The following is a description of a gene set: studied in species Homo sapiens Therapy with interferon-beta (IFN-beta) is a mainstay in the management of relapsing-remitting multiple sclerosis (MS), with proven long-term effectiveness and safety. Much has been learned about the molecular mechanisms of action of IFN-beta in the past years. Previous studies described more than a hundred genes to be modulated in expression in blood cells in response to the therapy. However, for many of these genes, the precise temporal expression pattern and the therapeutic relevance are unclear. We used Affymetrix microarrays to investigate in more detail the gene expression changes in peripheral blood mononuclear cells from MS patients receiving subcutaneous IFN-beta-1a. The blood samples were obtained longitudinally at five different time points up to 2 years after the start of therapy, and the patients were clinically followed up for 5 years. We examined the functions of the genes that were upregulated or downregulated at the transcript level after short-term or long-term treatment. Moreover, we analyzed their mutual interactions and their regulation by transcription factors. Compared to pretreatment levels, genes were identified as highly differentially expressed, many of them already after the first IFN-beta injection. The interactions between these genes form a large network with multiple feedback loops, indicating the complex crosstalk between innate and adaptive immune responses during therapy. We discuss the genes and biological processes that might be important to reduce disease activity by attenuating the proliferation of autoreactive immune cells and their migration into the central nervous system. In summary, we present novel insights that extend the current knowledge on the early and late pharmacodynamic effects of IFN-beta therapy and describe gene expression differences between the individual patients that reflect clinical heterogeneity. Human Gene Set: HECKER_IFNB1_TARGETS from publication Hecker M, Hartmann C, Kandulski O, Paap BK, Koczan D, Thiesen HJ, Zettl UK (PMID 23636981) Genes transcriptionally modulated in the blood of multiple sclerosis patients in response to subcutaneous treatment with recombinant IFNB1., and this is the list of marker genes: HES4, IFIT5, EIF2AK2, MX2, SCO2 (NCBI Gene Id 9997), SERPING1, PARP12, GZMB, PDZK1IP1, CXCL10, OASL, C1QB, LY6E, CMTM5, XAF1, KLRD1, SAMD9, MX1, RIGI, MMP25, SPON2, TNFAIP6, DDX60, OAS2, DHX58, CCL2, STAT1, TYMP, MMP9, C1QA, GBP1, CMTM2, RTP4, TCL1A, IFI6, C1QC, ISG15, HERC5, APOBEC3A, FFAR2 (NCBI Gene Id 2867), SIGLEC1, ARG1 (NCBI Gene Id 383), TMEM140, IFITM3P7, ZBP1, CCL8 (C-C motif chemokine ligand 8), IFI44, CD163, TREML1, DTX3L, G0S2, RPS23, CHI3L1, EPSTI1, LGALS3BP, C3AR1, EGR1, RSAD2, EGR2, LAMP3, CYP4F3, IFI35, MS4A4A, IRF7, GP9, CMPK2, SH3BGRL2, IFIT2, CLU, OAS3, APOBEC3B, JUP, PROS1, FCER1A, CABP5, HERC6, SAMD9L, LILRA3, PNPT1, IFIT3, IFIT1, MGAM, KCNJ15, IFI27, GGTA1, LAP3, CXCL8, IFI44L, PLSCR1, TRBV27, STAP1, MYL9, OAS1, PARP9, ITGA2B